Given this list of marker genes Akt2, Ythdf2, Mettl3, Pkp1 (plakophilin 1), Sh3bgrl, Nck1, here is a description of the gene set: Any process that activates or increases the frequency, rate or extent of cytoplasmic translational initiation. Mouse Gene Set: GOBP_POSITIVE_REGULATION_OF_CYTOPLASMIC_TRANSLATIONAL_INITIATION species: Mus musculus